Given this list of marker genes Plg, Bdnf, Mecp2, Ntrk2, Plat, Syt4, Slitrk5, here is a description of the gene set: Cell-cell signaling between presynapse and postsynapse mediated by brain-derived neurotrophic factor (BDNF) crossing the synaptic cleft. Mouse Gene Set: GOBP_TRANS_SYNAPTIC_SIGNALING_BY_BDNF studied in species Mus musculus